The following is a description of a gene set: studied in species Homo sapiens Genes predicted to be targets of miRBase v22 microRNA hsa-miR-4474-3p in miRDB v6.0 with MirTarget v4 prediction scores > 80 (high confidence targets). Human Gene Set: MIR4474_3P from publication Chen Y, Wang X (PMID 31504780), and this is the list of marker genes: RNF144B, RHOQ, CTSB, MRPS25, ALOX15, PAK5, SERP1, NLK, RNF41, RASSF8, ARNT2 (aryl hydrocarbon receptor nuclear translocator 2), SLC38A2, CLRN1, SCRT2 (scratch family transcriptional repressor 2), RBPJ, CADM1, CHD7, FNDC5, PARP8, SPIRE1, CGGBP1, ZNF589, ZNF773, DOK1, MBNL1, PRR14L, MRPL57, DUSP18, EHMT1, PIK3R1, PRDM9, DESI1, AHRR, ELOVL2, INSM1, EPHA3, STAC, TMEM216, CRIM1, RIMOC1, COL3A1, FBXW7, SCYL1, DENND1C, SLC45A4, RNF2, SYS1, RTL10, CDC7, ECHDC3, NAB1, MAP6, COL24A1, GINS3, METAP2, TBL1XR1, BCL11B, SCAF4, GRIK1, XPO4, TMEM52B, NPEPPS, PCDH9, HS6ST2, TRPC5, RAI2, PRDM7, PDE7A, SYT1, FAM210B, VPS29, ZFYVE26, TLR5, TMEM47, RAMP1, VAMP4, ADARB2, GJD3, CAPZA2, FASLG, ZNF480, MAOB, YWHAH, NAIP, DAB2, RABL6, ADIPOR2